The following is a description of a gene set: species: Homo sapiens Examples of transcription factors whose activities are regulated by MAPK7 phosphorylation. from publication Turjanski AG, Vaqué JP, Gutkind JS (PMID 17496919) The mitogen-activated protein kinases (MAPKs) are a family of serine/threonine kinases that play an essential role in signal transduction by modulating gene transcription in the nucleus in response to changes in the cellular environment. They include the extracellular signal-regulated protein kinases (ERK1 and ERK2); c-Jun N-terminal kinases (JNK1, JNK2, JNK3); p38s (p38alpha, p38beta, p38gamma, p38delta) and ERK5. The molecular events in which MAPKs function can be separated in discrete and yet interrelated steps: activation of the MAPK by their upstream kinases, changes in the subcellular localization of MAPKs, and recognition, binding and phosphorylation of MAPK downstream targets. The resulting pattern of gene expression will ultimately depend on the integration of the combinatorial signals provided by the temporal activation of each group of MAPKs. This review will focus on how the specificity of signal transmission by MAPKs is achieved by scaffolding molecules and by the presence of structural motifs in MAPKs that are dynamically regulated by phosphorylation and protein-protein interactions. We discuss also how MAPKs recognize and phosphorylate their target nuclear proteins, including transcription factors, co-activators and repressors and chromatin-remodeling molecules, thereby affecting an intricate balance of nuclear regulatory molecules that ultimately control gene expression in response to environmental cues. Human Gene Set: TURJANSKI_MAPK7_TARGETS, and this is the list of marker genes: MEF2C, FOSL1, ELK4, ETS1, MYC, FOS, MEF2A